The following is a description of a gene set: from publication Yamazaki K, Aso T, Ohnishi Y, Ohno M, Tamura K, Shuin T, Kitajima S, Nakabeppu Y (PMID 12604609) Elongin A is a transcription elongation factor that increases the overall rate of mRNA chain elongation by RNA polymerase II. To investigate the function of Elongin A in vivo, the two alleles of the Elongin A gene have been disrupted by homologous recombination in murine embryonic stem (ES) cells. The Elongin A-deficient ES cells are viable, but show a slow growth phenotype because they undergo a delayed mitosis. The cDNA microarray and RNase protection assay using the wild-type and Elongin A-deficient ES cells indicate that the expression of only a small subset of genes is affected in the mutant cells. Taken together, our results suggest that Elongin A regulates transcription of a subset but not all of genes and reveal a linkage between Elongin A function and cell cycle progression. Mouse Gene Set: YAMAZAKI_TCEB3_TARGETS_DN Genes down-regulated in embryonic stem cells from TCEB3 knockout mice. species: Mus musculus, and this is the list of marker genes: Ipo5, Kpna2 (karyopherin subunit alpha 2), Rfx2, Ube2s, Dsg2, Clybl, Uchl1, Ldhb, Zmym1, Rhox6, Trp53inp1, Dusp6, Sinhcaf, Strbp, Anxa1, Ruvbl2, Sox2, Emb, Pno1, Ybx1, Kcnk1, Cers4, Stoml2, Park7, Nusap1, Fibin, Zfp42, Vdac1, Fgd1, Mt2, Acly, Top2a, Vbp1, Swt1, Amigo3, Cbr3, Phb1, Esco2, Lbr, Pipox, Nelfb, Sycp3, Mybl2, Cdh3, Fkbp3, Ctbp2, Utf1, Manba (mannosidase, beta A, lysosomal), Tcf7, Zfp985, Serbp1, Dhcr24, Arl6ip1, Cmas, Psma2, Tuba1b, Dbf4, Dnmt1, Wasf3, Aldh7a1, Six4, Slc25a40, Syt9, Sorl1, Agr2, Cul2, Sod2, Nadk2, Gli1, Rps4l, Phyh, Dppa3, Hnrnpa1, Cks2 (NCBI Gene Id 66197), Cwf19l2, Pabir2, Gnpda1, Fzd5, Sephs2, Cdkn1c, Eno3, Igf2, G3bp1, Tubb2b, Sap30, Itm2a, Tgif1, Tubb4b (tubulin, beta 4B class IVB), Aldh2, Uhrf1, Kif11, Stag3, Akr1b1, Tfrc, Igfbp2, Laptm5, Xrcc5, Grb10, Aldoa, Mt1, Col18a1, Hsp90aa1, Adam23, Spp1, Nek2, Epcam, Ckb, Bclaf3, Psrc1, St13 (suppression of tumorigenicity 13), G2e3, Kif20a, Wwc1, Ash2l, Krt19, Sulf2, Hat1, Pmm1, Elavl2, Cldn4, Mccc2, Cbx7, Hmga1, Gm8016, Ltbp4, Zfp52, Zfp943, Trh, Cobl, Tfap2c, Pim1, Aktip, Snrpa1, Meg3, Aurka, Cdca7l, Carnmt1, Golga4, Ulk1, Apoe, Psip1, Arl4a, Tpd52, Eed, Agtrap, Ptch1, Pramel13, Dnajc21, Lgals3, Hmgcs1, Gclm, Fxr1, Gstm6, Fam25a, Osbpl1a, Tubb5, H2bc4, Cacna1a, Cyba, Ccne1, Ubxn2b, Mtf2, Map1b, Enah, Cct3, 1810059H22Rik, Adh5, Mdn1, Klf2, Rimklb, Cldn7, Msh6, Nasp, Mif, Cacna2d1, Nectin3, Fdft1, Rbm3, Ebna1bp2, Crabp1, Mir17hg, Spred1, Jade1, Zfand6, Gng2 (guanine nucleotide binding protein (G protein), gamma 2), Slc25a13, Ect2, Cdh1, Gstm1, Tcfl5, Cul4b, Gsta4, Spint2, Cpsf4l (NCBI Gene Id 76903), Taldo1, S100a6, Slc20a1, Diaph1, Septin1, Resf1, Ahsa1, Dpys, Ttc39b, Bub1b, Cpeb1, Tcl1, Jarid2, Rfc5, Ifitm6